The following is a description of a gene set: Mouse Gene Set: GOMF_NUCLEAR_ANDROGEN_RECEPTOR_BINDING studied in species Mus musculus Binding to a nuclear androgen receptor., and this is the list of marker genes: Pkn1, Zbtb7a, Rnf6, Ddx5, Kdm1a, Rnf4, Foxp1, Foxp2, Pias2, Prkcb, Prpf6, Ar, Tmf1, Kdm3a, Daxx (Fas death domain-associated protein), Trim68, Psmc3ip, Prmt2, Arid5a, Kdm5d, Rnf14, Tgfb1i1, Tcf21, Wipi1, Ncoa3 (nuclear receptor coactivator 3), Foxh1, Calr, Snw1, Park7, Smarca4, Nsd1, Kdm4c, Ep300